Given this list of marker genes MIR24-1, MIR133A1, LMNA, IGF1, MIR145, CTDP1, SMAD3, LMCD1, ACACB, TNFRSF1A, MIR19A, KDM4A, MIR1-1, TWF1, TNFRSF1B (TNF receptor superfamily member 1B), MLIP, MIR34B, PI16, YY1, ROCK2, MIR208A (NCBI Gene Id 406990), RAP1GDS1, TRIM63, GSK3A, MIR195, MYH7, RYR2, PAK1, MIR19B1, COL14A1, PRKCA, NOTCH1, ADRA1A, EDN1, MIR199B, HDAC4, HTR2B, ARRB2, ATP2B4, FOXP1, CAMTA2, RGS4, NR4A3, PARP2, GATA6, ADCY10, CERS1, MIR214, ATP2A2, MSTN, NPPA (natriuretic peptide A), CAV3, GLRX3, FOXO1, PRKG1, PARP1, PDLIM5, STUB1, GATA4, ERRFI1, ARRB1, MTPN, MIR25, HAND2, SLC9A1, PPARG, HEY2, LEP, GATA5, IGFBP5, AGT, MEF2A, MIR17, MIR21, MIR199A1, MYOC, IL6ST, APLNR, G6PD, SMAD4, EZH2, BMP10, PPARA, KLF15, TTN, AKAP6, MYMK, PAK2, INPP5F, SORBS2, CYBA, RGS2, BECN1, ROCK1 (Rho associated coiled-coil containing protein kinase 1), CSRP3, MEIS1, PPP3CA, TOMM70, MIR20A, HDAC2, MIR23A, MIR34C, CAMK2D, PDE9A, P2RX4, MIR15B, TCAP, MYH6, TRPC3, here is a description of the gene set: Human Gene Set: GOBP_MUSCLE_HYPERTROPHY The muscle system process that results in enlargement or overgrowth of all or part of a muscle organ due to an increase in the size of its muscle cells. Physiological hypertrophy is a normal process during development (it stops in cardiac muscle after adolescence) and can also be brought on in response to demand. In athletes cardiac and skeletal muscles undergo hypertrophy stimulated by increasing muscle activity on exercise. Smooth muscle cells in the uterus undergo hypertrophy during pregnancy. species: Homo sapiens